Given this list of marker genes FZD3, ROR1, WNT5A, FZD10, FZD6, FZD4, DVL1, FZD1, FZD2, FZD9, ROR2, FZD8, DVL3, FZD7, DVL2, FZD5, here is a description of the gene set: Human Gene Set: KEGG_MEDICUS_REFERENCE_WNT5A_ROR_SIGNALING_PATHWAY studied in species Homo sapiens Pathway Definition from KEGG: WNT5A -> (FZD,(ROR1,ROR2)) -> DVL WNT5A-ROR signaling pathway. Pathway ID: N01427. Pathway type: Reference. Pathway class: nt06505 WNT signaling.